Given this list of marker genes PEX12, OGT, PHAF1, ZNF609 (NCBI Gene Id 23060), IGF2BP2, MGST3, IBA57, NSD2, MMP15, APPBP2 (NCBI Gene Id 10513), QKI, DPP8, MDM4 (NCBI Gene Id 4194), AFG3L2, SLC26A9, SLC36A3, PPARGC1A, EFR3B, CEP85, MELTF, CERS6, ADIPOR2, MSI2, ONECUT2, DFFA, ABR, KRT10-AS1, MTMR11, FRMD5, SLC35E2B, DAG1, EPB41L4A, CDX1, DNAJC5G, TFRC, PCNX1, FTO, EFNA1 (NCBI Gene Id 1942), FABP7, NUCB1, KANSL3, UNC119B, EEF2K, PHTF2, ZBTB39, RBM4, DPYSL3, GABRB3, OSBPL10, TMEM120B, LRP4, TDRP, ABHD2, LDLRAD3 (low density lipoprotein receptor class A domain containing 3), APLP2, DPAGT1, LRP8, RAPGEFL1, YWHAG, IKZF3, ZNF831, RBM4B, PANK3, ATPAF2, FAM168A, RICTOR, ADAMTSL5, CRIPT, MGAT5B, SSH2, HEYL, YIPF6 (Yip1 domain family member 6), LRRC7, PSD2, VAT1, CYREN, ASCC2, CTDNEP1, YTHDC1, GLCE, RAB8B, CCN2, SOX5, GPN3, PLXNA4, WDR35, SFRP5, USP38, BCAP29, UPF2, PARP8, MMP14, KIAA1328, PLEKHA1, RGN, TAOK1, HMGA2, POLE, TMEM132D, CKS1B, TMBIM6, ARSD, HTR6, ST3GAL1, CLDN12, STX5, ETNK1, TMEM214, PTMS, MEOX1, SHISA6, RNF182, PSMA5, TTYH3, SGPL1, ZNF474, FKBP4, SMG1, DHCR24, GPI, UBE2I, TMEM86A, HOOK3, MRGPRF, KCNB1, ZSWIM6, CNKSR3, RPRD2, FAM89B, SLC23A2, TMC8, MTCL2, SPTB, GLIS3, HIF3A, ACTR3, WBP2NL, GPR176, PAPPA, here is a description of the gene set: Human Gene Set: MIR485_5P Genes predicted to be targets of miRBase v22 microRNA hsa-miR-485-5p in miRDB v6.0 with MirTarget v4 prediction scores > 80 (high confidence targets). from publication Chen Y, Wang X (PMID 31504780) species: Homo sapiens